Given this list of marker genes ACR, IZUMO1, IZUMO4, CD9, IZUMO2, IZUMO3, here is a description of the gene set: part of: Fertilization Reactome Pathway: Acrosome Reaction and Sperm:Oocyte Membrane Binding The acrosome reaction is stimulated by zona pellucida binding and subsequent downstream events, including Ca2+ influx. Proacrosin cleavage is the hallmark event of the acrosome reaction. After the acrosome reactome the sperm has passed through the cumulus cells and the zona pellucida. The membrane of the sperm head and the membrane of the oocyte are drawn together through the interaction of the sperm-bound protein Izumo and the ooctye CD9 membrane protein. species: Homo sapiens